The following is a description of a gene set: Human Gene Set: GOBP_NEGATIVE_REGULATION_OF_VASCULAR_WOUND_HEALING Any process that decreases the rate, frequency, or extent of blood vessel formation when new vessels emerge from the proliferation of pre-existing blood vessels and contribute to the series of events that restore integrity to damaged vasculature. studied in species Homo sapiens, and this is the list of marker genes: SERPINE1, MIR200B, MIR1298, TNF, ALOX5, MIR34A, TAFA5, SLC12A2